Given this list of marker genes GEMIN8, SRF, CLRN1, PPP3R1, MTSS1, CUL5, DUSP22, ATXN1, PTP4A1, CCDC141, GAB1, CYB5B, SORBS2, ZNF704, PRKCI, WASL, AP1M1, SLC25A37, TUBB2B, UFL1, RBBP9 (RB binding protein 9, serine hydrolase), EGR3, DLG2, EPAS1, NDFIP1, CHST1, ANKRD13A, MAPK8, ELAVL4, AATK, JAZF1, C9orf72, ADD1, EIF3A, KSR2, BNC2, SPIRE1, NRXN1, SPTBN1, ARF4, SP1, SOCS7, INO80C, CNOT6, SYDE1, CCR8, FOXO3, PAPSS2, CREB5, NAPB, NALF2, INO80D, DUSP3, ASXL3, BACH2, JAG1, VANGL1, SDC1, NPPA, PNPLA1, FLRT3, TSNAX, AKAIN1, ZNF483, RABGAP1, SYPL1, ME1, MSRB3, NPHS2, HRH4, USO1, CCDC28A, GSE1, TRPC4AP, TEX2, RAP2A, ZNF805, EIF3J, RLN2, MSANTD2, CORO1C, GPR12, AMIGO2, HAPLN4, ACOT11, NCKAP1, CYFIP1, SOCS6, ATF7, ENO4, ANKIB1, MAP7D2, ASRGL1, GPR6, DCUN1D1, CARF, DPY19L3, ZNF280B, SEC22C, BRWD3, CDC42BPA, IQCH, AK5, ZNF436, DENND1B, PBRM1, EGLN1, BRAF, FOXN2, HNRNPLL, PLK4, ATL2, EFNB1, FRS2, CAPN2, FILIP1L, REEP5, RTL9, FGF9, SEC31A, KPNA1 (NCBI Gene Id 3836), MAPRE1, MED28, NUFIP2, RAB32, here is a description of the gene set: species: Homo sapiens Human Gene Set: MIR196A_3P from publication Chen Y, Wang X (PMID 31504780) Genes predicted to be targets of miRBase v22 microRNA hsa-miR-196a-3p in miRDB v6.0 with MirTarget v4 prediction scores > 80 (high confidence targets).